Given this list of marker genes Gas2l1, Spast, Map4, Prune1, Gas2l2, Hspa1b, Stmnd1, Ska3 (spindle and kinetochore associated complex subunit 3), Stmn3, Clasp1, Cdh5 (NCBI Gene Id 12562), Htt, Fkbp4, Tubg2, Gda, Mapre1, Atxn7, Kif24, Ska2 (spindle and kinetochore associated complex subunit 2), Ankrd53, Togaram1, Arhgef7, Cdkn1b, Nckap5, Trpv4, Nde1, Pcnt, Abl1, Arhgef2, Clasp2, Camsap2, Camsap1, Bbof1, Wdr72, Mzt1, Spef1, Nav3, Met, Kif21a, Tppp2, Map6d1, Mapk8, Fbxo5, Apc2, Slc39a12, Htr1a, Tbcd, Tuba1a, Diaph3, Stmn4, Ccn2, Eml4, Tubgcp2, Zfp207, Kif2b, Wdr47, Map1s, Akap9, Trim54, Rp1, Stmn1, Hdac6, Tubgcp5, Ttbk2, Ccsap, Kif18a, Aurkb, Ckap5, Ccdc88c, Tubg1, Mapre3, Ssna1, Tppp3, Smn1, Clip3, Mapt, Map1b, Csnk1d, Numa1, Ska1, Dctn1, Arl2, Rps3, Mid1ip1, Rac1, Pak1, Camsap3, Kif19a, Cav1, Sgk1, Slain2, Cryab, Psrc1, Cib1, Fgf13, Clip1, Map7d3, Mecp2, Tubgcp6, Tppp, Ccdc66, Taok1, Ckap2, Rhoa, Tubgcp3, Apc, Stmn2, Golga2, Katnb1, Kif14, Nckap5l, Bmerb1, Arhgef1 (NCBI Gene Id 16801), Cenpj, Kif18b, Cep192, Ndel1 (nudE neurodevelopment protein 1 like 1), Nin, Tubb1, Nme7, Cav3, Slain1, Fes, Eml2, Pde4dip, Snca, Hdgfl3, Inpp5j, Drg1, Mapre2, Dyrk1a (dual-specificity tyrosine phosphorylation regulated kinase 1a), Tubgcp4, Gba2, Ccdc57, Map1a, Hspa1a, Nedd1, Git1, Specc1l, Map2, Haus2, Cdk5rap2, Kif2c, Mid1, Tpx2, Tubb4a, here is a description of the gene set: Assembly or disassembly of microtubules by the addition or removal of tubulin heterodimers from a microtubule. Mouse Gene Set: GOBP_MICROTUBULE_POLYMERIZATION_OR_DEPOLYMERIZATION species: Mus musculus